The following is a description of a gene set: studied in species Mus musculus Mouse Gene Set: GOBP_POSITIVE_REGULATION_OF_NEURONAL_ACTION_POTENTIAL Any process that activates or increases the frequency, rate or extent of neuronal action potential., and this is the list of marker genes: Ffar3, Pawr, Rapgef4, Cntnap2, Gba1